The following is a description of a gene set: Mouse Gene Set: GOBP_POSITIVE_REGULATION_OF_VASCULAR_ENDOTHELIAL_CELL_PROLIFERATION Any process that activates or increases the frequency, rate or extent of vascular endothelial cell proliferation. species: Mus musculus, and this is the list of marker genes: Igf2, Plcg1, Adam17, Col18a1, Itga4, Prok1, Hmgb1, Fgf2, Mdk, Akt3, Dicer1, Nrarp, Sp1, Fgfr1, Apln, Sirt6, Ghsr, Igf1, Ghrl, Pdpk1, Stat3